The following is a description of a gene set: Budding and maturation of HIV virion species: Homo sapiens Human Gene Set: REACTOME_BUDDING_AND_MATURATION_OF_HIV_VIRION, and this is the list of marker genes: VPS28, CHMP7, VPS37D, TSG101, MVB12A, PDCD6IP, VPS37C, VPS37B, UBA52, VPS37A, PPIA, CHMP4A, CHMP2B, UBC, CHMP4B, CHMP3, MVB12B, CHMP5, UBAP1, NEDD4L, CHMP2A, VTA1, CHMP6, CHMP4C, RPS27A, VPS4A, UBB (ubiquitin B), VPS4B